Given this list of marker genes TRAPPC12, MKRN1, UPF2 (NCBI Gene Id 26019), C1orf198, EID2, EGF, CD44, FIGNL1, FAM13B, ZFR, SAMD9L, PAIP2, LIPT2, CIRBP, FAM169A, OSBPL3, INTS6, SMS, KLHDC8B, CFAP184, ARHGDIG, NOTCH2, PRSS37, GRM3, NDFIP1, TNS1, HEPACAM2, SYNE1, ZNF600, EAF2, DPP4, IVNS1ABP, GOLM2, ATF7IP, HAO1, LINC00511, ALDH2, UNC119B, REV3L, RSF1, RC3H2, MTERF2, HOXB13, ACTR3B, IKZF1, TMEM35A, CCDC25, ZKSCAN1, XRCC6, TPH2, DLX2, SLC38A9, RNF14 (ring finger protein 14), INSL5, TULP4, ZGRF1, HLA-B (NCBI Gene Id 730410, major histocompatibility complex, class I, B), CWC22, UNC5CL, GBP6, OLAH, FAM174B, DMWD, APBB1IP, SHC3 (SHC adaptor protein 3), IGF2R, DCDC2B, CTCF, TTC33, PTPDC1, HAVCR1, USP42, DDX42, TRPV2, SYN3, OGA, CAMSAP1, SH3YL1, DCAF12L1, SLC25A40, SVIP, RAG2, SFR1 (NCBI Gene Id 119392), SIMC1, TP53BP2, MTDH, HMGXB4, TIMP2, OASL, KMT5B, RESF1, DGKI, ZCCHC2, SPATA7, IL17RA, PDS5A (NCBI Gene Id 23244), SNHG8, ZNF512B, IMMP2L, TOB1, RFX7, DNAH8, VEGFA, EXOC6, HOXB1, PRM3, DDX4, FAM184A, CEP126, RNF11, INSIG1, LONRF1, PPM1E, LMO2, SPACA1, C3orf62, RNF19A, TEX11, ST8SIA2, ECT2, SERPINB9, TMT1A, WDR44, NIPAL3, CDKN2C (cyclin dependent kinase inhibitor 2C), MAFK, PRRT1, PITPNC1, MFSD8, BAZ2A, UTY, PRKAR2A, MOB4, CCDC171, GJA3, CPXM1, SORCS2, ZNF236, GGA3 (golgi associated, gamma adaptin ear containing, ARF binding protein 3), EIF1AD, CAMK1D (NCBI Gene Id 57118), NSD3, OTUD1, RBAK, SETD3, FRYL, JMJD1C, INSYN2B, IL31RA, CCDC88C, EEF1A2, FYB1, HILPDA, DDX3Y, TMEM74, ARL2BP, SNX29, UMODL1, BTRC, SRCAP, KMT2C, ARGLU1, JADE2, GPR174, WDR35, MPPED2, MYOG, CEP164, TRAF3IP2, LCOR, UNKL, CYLD, SOX30, CLDN10, BAG4, ATP12A, TENM2, BCL11A (NCBI Gene Id 55085), SERINC1, PGM2L1, UTP23, DCTN6 (dynactin subunit 6), VPS13A, COX16, FGFR1OP2, CHD8, TPST1, MSL2, ZCCHC18, CYP2R1, TFDP2, RAB33A, GSTA5, KIF16B (kinesin family member 16B), B3GALT5, CDK20, DPYS, ANKRD12, MKRN3, H3C4, here is a description of the gene set: CD4 T cell help is critical for both the generation and maintenance of germinal centers, and T follicular helper (TFH) cells are the CD4 T cell subset required for this process. SAP (SH2D1A) expression in CD4 T cells is essential for germinal center development. However, SAP-deficient mice have only a moderate defect in TFH differentiation as defined by common TFH surface markers. CXCR5+ TFH cells are found within the germinal center as well as along the boundary regions of T/B cell zones. Here we show that germinal center associated T cells (GC TFH) can be identified by their co-expression of CXCR5 and the GL7 epitope, allowing for phenotypic and functional analysis of TFH and GC TFH populations. Here we show GC TFH are a functionally discrete subset of further polarized TFH cells, with enhanced B cell help capacity and a specialized ability to produce IL-4 in a TH2-independent manner. Strikingly, SAP-deficient mice have an absence of the GC TFH subset and SAP- TFH are defective in IL-4 and IL-21 production. We further demonstrate that SLAM (Slamf1, CD150), a surface receptor that utilizes SAP signaling, is specifically required for IL-4 production by GC TFH. GC TFH cells require IL-4 and IL-21 production for optimal help to B cells. These data illustrate complexities of SAP-dependent SLAM family receptor signaling, revealing a prominent role for SLAM receptor ligation in IL-4 production by germinal center CD4 T cells but not in TFH and GC TFH differentiation. Human Gene Set: GSE21379_TFH_VS_NON_TFH_CD4_TCELL_UP from publication Yusuf I, Kageyama R, Monticelli L, Johnston RJ, Ditoro D, Hansen K, Barnett B, Crotty S (PMID 20525889) species: Homo sapiens Genes up-regulated in CD4 follicular helper T cells (Tfh) versus non-Tfh.